The following is a description of a gene set: Human Gene Set: GOBP_CELLULAR_RESPONSE_TO_GONADOTROPIN_STIMULUS Any process that results in a change in state or activity of a cell (in terms of movement, secretion, enzyme production, gene expression, etc.) as a result of a gonadotropin stimulus. studied in species Homo sapiens, and this is the list of marker genes: GATA6, EPHA8, WT1, EFNA5, EDNRA, LHCGR, POR, INHBA, NSMF, CCNA2, SCX, GATA1, SLC5A5, GCLM, FSHR, TOP1, NOTCH1, GCLC, PAX8, EDN1 (NCBI Gene Id 1906)